Given this list of marker genes PLG, LTBP3, TGFB2, TGFB1, LTBP1, LTBP4, TGFB3, FBN1, here is a description of the gene set: Plasmin mediated activation of latent TGF-beta. Pathway ID: N01460. Pathway type: Reference. Pathway class: nt06507 TGFB signaling. Pathway Definition from KEGG: PLG -> FBN1 == LTBP1/3/4 // TGFB studied in species Homo sapiens Human Gene Set: KEGG_MEDICUS_REFERENCE_PLASMIN_MEDIATED_ACTIVATION_OF_LATENT_TGF_BETA